Given this list of marker genes DCK, GMPS, UPP1, PRPS2, IMPDH1, DHODH, ADK, ADSL, AMPD3, CAD, PRPS1L1, NUDT2, AMPD1 (adenosine monophosphate deaminase 1), IMPDH2, PPAT, CDA, PRPS1, UMPS, UCK2, GART, ADA, ADSS1, UCK1, PAICS, PFAS, AMPD2, UPRT, APRT, UPP2, ATIC, HPRT1, ADSS2, RFK (riboflavin kinase), CMPK1, UCKL1, here is a description of the gene set: species: Homo sapiens The chemical reactions and pathways resulting in the formation of a ribonucleoside monophosphate, a compound consisting of a nucleobase linked to a ribose sugar esterified with phosphate on the sugar. Human Gene Set: GOBP_RIBONUCLEOSIDE_MONOPHOSPHATE_BIOSYNTHETIC_PROCESS